Given this list of marker genes COL6A5, PCOLCE, LOXL4, COL3A1, CTSS, COL15A1, LOXL3, DST, TLL2, COL1A1, COL11A1, COL11A2 (collagen type XI alpha 2 chain), PXDN, COL5A1, LOXL2, COL6A6, COL4A3, COL6A3, COL4A1, COL9A2, LOX, CD151, COL7A1, PLEC, COL4A5, LAMA3, COL6A2, ITGB4, COL1A2, COL8A2, COL24A1, MMP13, COL14A1, COL12A1, COL2A1, COL5A3, COL5A2, CTSV, COL9A1, LAMC2 (laminin subunit gamma 2), LOXL1, COL9A3, MMP9, COL10A1, ITGA6, COL4A6, TLL1, MMP3, BMP1, COL18A1, COL8A1, CTSB, CTSL, COL27A1, COL17A1, LAMB3, COL6A1, MMP7, COL4A4, COL4A2, MMP20, here is a description of the gene set: Human Gene Set: REACTOME_ASSEMBLY_OF_COLLAGEN_FIBRILS_AND_OTHER_MULTIMERIC_STRUCTURES Assembly of collagen fibrils and other multimeric structures species: Homo sapiens